Given this list of marker genes STARD4, TSPOAP1, FDX1, STARD6, STARD3, CYP11A1, TSPO, FDX2, STAR, FDXR, STARD3NL, AKR1B1, here is a description of the gene set: Human Gene Set: REACTOME_PREGNENOLONE_BIOSYNTHESIS studied in species Homo sapiens Pregnenolone biosynthesis